Given this list of marker genes NCL, AFF1, CAAP1, RAE1, ZNF484, GSE1 (Gse1 coiled-coil protein), LINC01970, CCDC142, BBOF1, LRRC57, WBP2, FAM227B, ATP8B1, MDP1, TSPYL4, ZSWIM4, SLC35A3 (NCBI Gene Id 23443), EXOSC2, TRAPPC1 (trafficking protein particle complex subunit 1), TOMM20L-DT, NAPA, TBP, CD55, ZNF33A, PUS1, RUVBL2, IQGAP3, MRPL57 (mitochondrial ribosomal protein L57), HNRNPD, RUFY1, TARS2, EDC3, MRPS18C, NCDN, LINC01465, PLK3, POC1B, FMN1, CEP44, COQ5, KBTBD4, ABCF2, CTDSP2, DNAJC16, TEN1-CDK3, SCAMP2, TIPARP, GTF2H4, DESI2, PCNX4-DT (NCBI Gene Id 105370524), SNHG12, ROPN1L (rhophilin associated tail protein 1 like), RACK1, TMEM170A, CCT6B, POLG, METTL8, LINC02851, RPL30P11, PNKP, MIS12, HEXIM1, PSMA4, PCM1, HELQ, RGL1, ZFC3H1, DHDH, ACIN1, DAG1, VRK3, FAM201A, SCYL2 (SCY1 like pseudokinase 2), RRS1-DT, SELENOW, PLD3, IFRD2, MSH5, DUSP19, MTERF3, CTU1, RMI1, SUPT7L, COX20, TTC7A, DRAIC, SLC25A39, ASCC2, MRM1, SNORD95, PLA2G4C, ARID2, TCP1, MRPL2, ALKBH7, MRRF, OCEL1, ZBTB48, MCFD2, ATF7IP, EIF4A1, PARP2 (poly(ADP-ribose) polymerase 2), SNX29, SLC25A42, SDHAF1, MRPS31P4, SIKE1 (NCBI Gene Id 80143), ATP10B, CNTLN, ACSS2, RNF20, ANKS1A, RNF10, CLCN3, BLOC1S3, CPSF2, ZNF3 (zinc finger protein 3), DELE1, RPS26, SLC52A3, SLC25A23, MORF4L2, POLK, LINC02427, C14orf119, TTC14, SKA3, ING1, GOSR1 (NCBI Gene Id 9527), HAPSTR1, APEX1, AHI1, CEP164, MIPEPP3, MIPEP, BRIP1, NRAV, ASH2L, POLG-DT, TUFM, TMOD3, COX6A1, ELL, NDUFS2, CORO7, MTFR1L, KLC4, SMG9, FDXACB1, ZNF428, HEXA-AS1, RSBN1L, ZNF77, MTHFR, TTC14-DT, TMEM259, FBXL5, ZNF394, PHB2, EMC10, PWWP2A, HSPA9, MVK, ZNF830, RPL7L1, SLC26A2, RSRP1, RN7SL774P, DPY19L4, GTF2IRD1P1, G3BP2, HAUS2, GABARAP, HYKK, RBM18, GSTCD, PIWIL2, APTR, MSH5-SAPCD1, PKMYT1, LRRC59, PSMD9, PLPP5, ENSG00000273828, SEPTIN7P14, MCEE, ITPKA, TMEM191A, RRS1 (NCBI Gene Id 90810), WDR74 (NCBI Gene Id 54663), NPIPB2, PXN-AS1, EHF, MCM7, PPP2R3B, NGDN, CSNK1D, LDHA, ALKBH6, ANKRD18A, TMEM9B, FBXO33, PRPF38B, NOP56, H3P41, PPAN, PPAN-P2RY11, FUT8, FBXO8, YTHDF2, FBXL17, GARIN5A, UBE2L6, KDM4C, NDC1, HNRNPK, SH3BGRL2, MIR6853, RN7SL346P, MYG1, COA6, SLC4A1AP, MEMO1, GNB2, TMEM126A, COA6-AS1, AP3M2, TRMO, HSD17B12, CCZ1B, SNHG15, ACAD9, STK19, MYCL, ZNF600, CALR, DBT, CCM2, MRPL16, MED1, GYS1, VPS26C, PSMF1, SC5D, PRELID1, FAU, CHEK1, RPS15, NDUFA3, STXBP3, VPS39-DT, RLIG1, PARP8, NEIL1, MRPL19, OSCAR, HTRA2, CEP131, SFXN5, GCLC, ZCCHC9, LINC02453, ENSG00000267698, ITGB1-DT (NCBI Gene Id 101929475), GATAD2A, TMEM192 (transmembrane protein 192), DNAL1, SERTAD3, DDX21, BDNF-AS, NPAT, H4C1, TRAPPC6A, PRKAR1A, HAUS8, EPHA1, TIMM22, CERT1, PCLAF, LPCAT3 (NCBI Gene Id 10162), MIR5787, EIF2A, HACD1, C2CD3, ITGB1, SCAI (NCBI Gene Id 286205), ARFIP1, ZNF581, CD274, NDUFV1, SKP1, NEURL4, FCF1, VPS39, NDUFV1-DT, IFNGR1, RAB24, MPHOSPH10, TIPARP-AS1, TTC31, AP4M1 (adaptor related protein complex 4 subunit mu 1), SGF29, PICK1 (NCBI Gene Id 9463), ANKHD1-EIF4EBP3 (ANKHD1-EIF4EBP3 readthrough), PSMB7, PGAP4, TRABD2A, PNRC2 (proline rich nuclear receptor coactivator 2), GSTZ1, PSMA2, EMC6, XXYLT1, SDCBP2, FKBP2, KIF3A, PRPF3, G3BP1, FAM185BP, TOMM5, ANKHD1, ACOX1, HMBOX1, WRAP53, HNMT, ATM, DYNLL1, SLC35C2, SLC49A4, RNF216, CEP152, KLHL7 (NCBI Gene Id 55975), USO1, B3GAT3, EMG1, ATP6V1B2 (ATPase H+ transporting V1 subunit B2), H4C2, STAP2, MORF4L2-AS1, MAP4K1, CNBD2, TMEM9B-AS1, ERCC1, KRT8 (NCBI Gene Id 90177, keratin 8), ATAD2B, USE1, TMED4, C1orf43, CACNA2D4, XPO1, SKA1, TMEM39A, SOCS2, CDV3, TEN1 (NCBI Gene Id 100134934), MRPL35, TRMT44, MRPL32, PKP2, PSMD8, ATF7-NPFF, ABCC10, MAST4, ARPC5, CITED2, NGRN, WDR53, TBL3, C19orf47, GTF2IP12 (general transcription factor IIi pseudogene 12), ZNF107, ZCCHC2, DPCD, CATSPERG, REXO5, DEPDC4, MED29, UGGT1, KLHL20, NWD1, MPND, CC2D1B, MXI1, TSPAN8, RNU6-2, FRMD5, TM9SF1, SLC35E4, ACBD3, NFYA, DTWD2, FXR2, CUL5, RPS17, MIR4521, WASF2, NDUFS3, TRIM2 (NCBI Gene Id 23321), CDC73, HEXA, NUTF2, RRAGC-DT, DNAJA3, CCDC25, MAPK7, TSR1, CYP51A1-AS1, EAF2, CHD8, APPBP2, ILF3, GUK1, SH2B1, MIR4734, FAM83C-AS1, OMA1 (NCBI Gene Id 115209), TMEM102, FAM117B, ENPP3, KRBA2, SNORA16A, CAPN10, NOPCHAP1, LINC00938, CSF1, TENT4A, AHI1-DT, ZNF451, EIF3K, IQCC, SEPTIN4-AS1, FARP2, C8G, NUP42, FAS (Fas cell surface death receptor), CREB3, DAB1, MIR194-2HG, ABCB8, CFAP69, COMMD10, MSL2, PPP1R12B, CASP9, RPS3A, THAP2, RPPH1, AOPEP, CCND2, KPNA3, NABP2, DCP1B, RPLP0, EXOC6B, NF2, SAMD12, VAMP1, SLC25A45, APPBP2-DT, SERP1, FAM200B, UBLCP1, AUP1, PUS1-AS1, ARIH2, RABIF, YBX1, SS18, TTC17, PPP1R11, ABCC3, EFCAB14, RPA2, PAF1, DCAF17, HARS1, SRRM2, PLEKHA6, ENKUR, RHBDD1, VTA1, SAE1, VARS2, POLR1B (NCBI Gene Id 88998), DSE, S100A6, IQCB1, SURF6, ATF7, LSM8, ACTR8, OARD1 (O-acyl-ADP-ribose deacylase 1), DHPS, HSPBAP1, MRPL49 (NCBI Gene Id 740), ERI2, SAMD4B, MIRLET7I, SMC3, MRPL21, DTWD1, ENSG00000275765, TUBD1, CENPM, IMPDH2, GCNT3 (glucosaminyl (N-acetyl) transferase 3, mucin type), USP42, MORN1, INTS12, PHACTR4, COMMD1, LIN7C, SCAMP1, TRIM37, AREL1, CYP51A1, MRPS15, LRP6, CCDC125, NOP2, TM2D3, MLF2, CDCA7L, GBF1, HNRNPC, CCDC146, ASCC3, NBN, TUBGCP6, KNSTRN, NOLC1, B9D1, C12orf76, ITFG2-AS1, MAST4-AS1, SAR1B, FUCA1, HNRNPD-DT, DDX1, TIGD4, LINC01623, KIN, RPS6KB1, ITFG2, TPD52, CIC, ZNF391, PGK1 (phosphoglycerate kinase 1), MBD2, ENSG00000265246, TPD52L2, YJU2, PCNX4, GMCL1, SP3, NIPAL1, ENC1, MRPL18, DYRK2, HMOX1, MRPS31, SRRT (serrate, RNA effector molecule), CREBL2, RPL10, PMM2, DERL2, RNU2-2P, ETFBKMT, PPME1, INIP, NAPRT, TP53, RER1, RPS26P29, MSMP, ZSCAN20, PLEKHM3, MYO10, CPLANE2, TLN1, MANCR, EHBP1, SEC24C, DNAJB1, CARNMT1, COQ10A, HARS2, CTR9, ZBTB26, TOB2, EIF6, TRIP11, ARV1, C19orf48P, INTS9, KLHL7-DT, HECTD4, PFAS, RBM6, GNAI3, FANCE, AK3, KCNK1, CEP350, THUMPD1, VILL, WIPF2, RBM3, CNTROB, VIPR1-AS1, RPS27L, SRSF2, MED23, TTC13, RALB, TMEM50A, BCAS3, WDR41, PRP4K, ATP5MC2, NASP, COPS7A, RPL29, EDEM2, EHD4, NRBF2, RHEBL1, SEC31A, CARS2, TSPAN31, NDUFB1, CD44, NSD3, MYO9B (NCBI Gene Id 4650), VTRNA1-2, ATP5F1C, RPL24, FBXO45, CFAP68, METTL13, MFSD11, OSGEP, PSMB1, VRK2, INTS5, CLCN6, WDR89 (NCBI Gene Id 112840), LINC00471, LINC02901, ZNF473, MYCBP, SYF2, KIAA0319L, BBC3, SGTB, RABGEF1, ILF3-DT, FBXW5, MAN2A2, CKMT2-AS1, RPS7, TEDC1, UBAP2L, PAQR4, DXO, COQ6, ACOX3, DDX46, SYN2, AP1S3, CDC7, DUSP10, TRAPPC8, DNAJC21, TMEM70, IP6K2, HAGH, THNSL1, here is a description of the gene set: Genes containing one or more binding sites for (ARNT2) in their promoter regions (TSS -1000,+100 bp) as identified by GTRD version 20.06 ChIP-seq harmonization. species: Homo sapiens from publication Yevshin I, Sharipov R, Kolmykov S, Kondrakhin Y, Kolpakov F (PMID 30445619) Human Gene Set: ARNT2_TARGET_GENES